The following is a description of a gene set: Binding to an identical protein to form a homodimer. species: Homo sapiens Human Gene Set: GOMF_PROTEIN_HOMODIMERIZATION_ACTIVITY, and this is the list of marker genes: ZNF318, IZUMO3, RAG1 (recombination activating 1), ACP3, CLTRN, ATG7, STARD3NL, IMPA1, PDXK, TYRP1, THBS1, PARK7, RIPK2, PEX11A, DEFA3, BOK, AMBP, MGLL, GPRASP3, BCL11A, KCNN2, TFAP4, WDR54, PDLIM4, AHR, FLRT3, NR4A3, TBC1D22A, PRPS1L1, PDCD6IP, NLGN4X, RPE, BANF1, DUSP29, PECAM1, FOXP3, SPPL3, IRAK3, PDXP, TOX3, SH3GLB1, HNF4A, GDNF, DIAPH3, HM13, RUNX1, TMEM132A, UGT1A4, CRPPA, SPPL2B, RBPMS2, SYNDIG1, MTHFD1L, GCA, NADK2, MECOM, TPD52L1, DCK, ECT2 (NCBI Gene Id 55710), STING1, CST7, ZDHHC2, ITPR1, UGT1A5, TCF3, IRAK1, SNX2, CREB3L3, XPA, PDGFB, SETMAR, PRPS1 (phosphoribosyl pyrophosphate synthetase 1), AIMP1, DGKD, ERP29, HTN3, GALE, HAND1, IKZF3, APOA4, PRMT8, AOX1, ASMT, BLOC1S6 (biogenesis of lysosomal organelles complex 1 subunit 6), DROSHA, PDGFRA, BNIP3L, CBS, STK25, TFRC, RBM11, GSTM4, SLC4A1, ABCB10, ZHX2, HSPB8, EEA1, COMMD1, JUP, LHPP, PADI2, CDSN, ST3GAL2, JDP2, RNF40, PML, CCDC66, GPD1, VEGFA, GNPTG, FCER1G, IRF3, HEYL, SLC11A1, ACVR1, MIXL1, GSTM1, PIP4K2A, ACHE, UGT1A8, MYOM1, CHMP4A, MFF, DDIT3, RRAGA, VAPA (NCBI Gene Id 9218), TENM3, ENDOG, ZNF397, GIMAP7, CR2, CARNMT1, TWIST1, TNNC1, SUPV3L1, ZBTB1, HOOK1, S100P, TKT, NUDT16, CAMK2A, ENO1, S100A11, ABCG1, CREB3, UGT1A1 (NCBI Gene Id 54658), PEX11B, USF2, MAG, TBX15, PDGFC, CDADC1, BAX, JAM3, TENM2, HIP1, PRKRA, FLNA, GCH1, NR2C1, GBP2, PON1, CAMK2D, ADRA2A, LILRB1, NECTIN1, RABEP1, SLC25A14 (solute carrier family 25 member 14), HOGA1, SMAD3, ZHX3, RASIP1, ATF2, CD4, SNX6, FLT4, MKLN1, S100A10, SP100, AGXT, HVCN1, TPCN1, MAP3K9, PKM, ARMCX5-GPRASP2, KYAT1, SRM, NEUROG1, XCL1, MTPAP, APOA2, HAND2, S100B, MMUT, SHMT1, TARBP2, ACOD1, KIF20B, FBLN5, ENG (endoglin, NCBI Gene Id 2022), ADRB3, YARS2, SDCBP2 (syndecan binding protein 2), MIGA2, SYT6, NTRK2, ZNF365, DARS2, GLDC, PAPSS1, CCL5, TTN, RAP1GAP, CASQ2, NR0B1, STAT1, KLRF2, PAFAH1B2, TGFB2, TPST1, HPGDS, S100A5, PSAP, S100A16, VPS25, DPYD, CEBPB, HSPB1, HSP90AB1, PTH1R, MTCL1, APP, ADA2, CEP131 (NCBI Gene Id 22994), CRYL1, TERT, ACTN4, ADCY8, IL17A (NCBI Gene Id 94918), SMCHD1, ODC1, TMEM266, SERPINF2, PHETA1, KCNN4, NUDT16L1, MMACHC, RELA, SLC8B1, HES1, PARP1, IDE, G6PD (glucose-6-phosphate dehydrogenase), INHBB, STK19, STUB1, XPNPEP3, APPL2, TPM1, ISCU, EXT1, ATF3, RAB11FIP2, FGFR1, UGT1A7, FMR1, ACOX2, WRN, CASR, HSD17B4, DNPH1, CARS1, ADRA2C, ACSL6, BHLHE41, JCHAIN, PAFAH1B3, MORC2, ACTN1, COL9A3, NR6A1, FUT9, CRYM, IL17F, PON3, ST6GAL1, SDS, DEFA6, CLEC2A, CEACAM5, ALDH1A3, ABCB7, TIMM9, PYCARD, AADAT, PKD2, PDGFA, CCDC103, GLB1, RABL3, PTPA, DPY30, SRGAP2C, IZUMO1, COQ9, PIP4K2B, ERN1, PPCS, CAT, GPD1L, NOG, SMAD4, ELAVL1, GRHL1, TP53BP2, SCARB2, GBP1, DAB2IP, APOA1, SNF8, PHETA2, TFAP2B, PANK3, MAP3K12, PTGS2 (prostaglandin-endoperoxide synthase 2), EIF2AK1, SOHLH1, THAP1, MUC13, LRP4, TXN, TAP1, ENPP1, C16orf89 (NCBI Gene Id 146556), PRTFDC1, SLK, TYW5, MID1, KNSTRN, SCLY, S100A1, IL17D, LCT, HPS4, EPM2A, MYH9 (myosin heavy chain 9), MSH6, HIP1R (NCBI Gene Id 9026), CRYAB, DCLRE1B, ACOT7, CHRNA7, MYOM3, NPC1L1, PLD6, FXR2, APOE, NUDT21, RAB11FIP3, GRPEL2, NR2F2, MAP3K11, CEP43 (NCBI Gene Id 11116), STK26, CITED1, GSTZ1, CEACAM1 (NCBI Gene Id 634), MMAA, CISD2 (NCBI Gene Id 56831), NAA60, ACADL, LYRM4, TPPP, CHUK, DPP4, EXD1, CACYBP, GUCY2D, S100A13, PGRMC1, TSG101, ABCD1, ADAM10 (NCBI Gene Id 102), NKX2-5, TREX1, BAK1, PTPRO, KYAT3, ECE1, RTN4, NOS2, IRAK2, TESC, AMHR2, MTMR1, UGT1A9, CPQ, APPL1, TLR9, THRSP, PSMF1, NRF1, CD300H, TPM4, FZD4, BST2, CSF1, MGAT4A, PHB2, FIBIN, TYROBP, CIB2, GYG1, USF1, NQO2, ATP2A1, SARS1, TMEM192, SRR, NPM1, TPD52L2, TPM2, RUVBL2, TPI1, DEFA5, TM4SF19, ABCD2, ANO1, SLC5A5, CHEK2, NR0B2, MSH2, TXNRD2, TPST2, MSTN, DNM1L, ERBB4, BHLHE40, F11R, SSBP1, CARD9, EPHX2, GBP3, SEPHS1, MLXIPL, IL6R, GID8, SOX6, POU3F3, UCP2, TPR, TIMM10, VAPB, PDCD6, DGAT2, FXR1, RACK1, WARS1, HNF1B, UGT1A6, HSD11B1, CNOT9, TSSK4, NRBP1, IDH1, UGT1A10, SRF, LPL, SNRPC (NCBI Gene Id 6631), HMGCS1, COL9A1, MAP3K13, ACOX1, QTRT2 (queuine tRNA-ribosyltransferase accessory subunit 2), CIDEA, TYR, XDH, ARNT, SLC3A2, TP53I3, CADM3, UGT1A3, CEP135, BLTP3B, MGAT2, SOD1, MSI1, CLCN1, ABCG2, NUDT5, S100Z, LRRFIP1, GZMA, MAP3K21, KCNH2, PDCD10, MSH3, ADD2, SMIM1, PCYT1A, COL2A1, CARD8, SP1, SFPQ, MYOD1, SLC25A27, ROM1, MZF1, ADIPOQ, HSPB6, PRPH2, MVD, MIGA1, PRDM9, PTPRT, RRM2, CEBPA, PSPH, SEPTIN12, WWTR1, TERF2, ZBTB7B, HESX1, GSTM2, DGCR8 (NCBI Gene Id 66034), HSD17B1, PITX2, HPD, CYP2R1, EXT2, RAB11FIP4, BIRC5, TBX18, CORO1A, FBXO4, TREX2, GTF2A2, RNF8, NECTIN2, TSC2 (TSC complex subunit 2), EPRS1, CAMK2B, ADRB2 (NCBI Gene Id 154), HARS1, MME, RBPMS, GBP5, TBX1, PDK2, SLC33A1, ZBTB4, CHMP4C, STOM, PANK1, TARS2, CEP57, BLM, PLEK (pleckstrin), ZBTB38, MLX, GSS, GLCE, DAPK3, PDE2A, TRNT1, GREM1 (NCBI Gene Id 7947), SPPL2A, CSF1R, SNX9, KYNU, MAPK4, MASP1, SOHLH2, CISD1 (CDGSH iron sulfur domain 1), NECTIN3, NFS1, RBM44, SPPL2C, DNTTIP1, SYNE1, ADD1, GHR, UXS1, TOP2A, DSCAML1, NOD1, HHEX, RIPK1, QTRT1, EFEMP2, AMELX, RCHY1, CDA, GSTA4, HNF1A, SLC30A8, BARD1, PEX7, MAP3K5, SLC39A13, HMOX1, INPP5F, ENSG00000274276, FAP, CBY1, CPOX, STK10, IMPA2, VIL1, CHKA, ABCG4, STK4, B2M, ZNF174, GRM6, HSP90AA1, ALDH3A2 (aldehyde dehydrogenase 3 family member A2), HLA-G, NPR3, TENM4, KIT, CIP2A, PRMT2, SLC51A, MID2, PLN, FICD, SLC26A5, ABCD3, KLHL7, IKBKB (inhibitor of nuclear factor kappa B kinase subunit beta), OXA1L, UBA5, GRHPR, TRPC6, KARS1, DAXX, PNPO, VWA1, FOXP2, JAML, AXIN1, MYO9B, GLIPR2, GLA, ZBTB16, LILRB2 (leukocyte immunoglobulin like receptor B2), ALS2, GOLGA5, GALM, TENM1, CAV2, CALCOCO2, KMT2A, CAMK2G (NCBI Gene Id 818), VPS4B, GSTM3, ATIC, RDH5, DEFA4, COL9A2, SYT10, BNIP3, BMPR1A, DNM1, ERCC5, NAALADL1 (NCBI Gene Id 10004), MAP3K10, STARD3, UPB1, NFE4, CD247, MTUS2, SNX1, TRIM8, FZD9, GRPEL1, ZNF396, STAT5B, NAGA, TRIM5, GBP4, GGCT, STAT3, NLRC4, GADD45A, TMIGD1, CENPF (NCBI Gene Id 51468), GEN1, MFSD1, PSMD7, GDF15, PAXX, CADM1, TPD52, S100A6, NTRK1, TRIM9 (tripartite motif containing 9), NACC2, PON2 (paraoxonase 2), HIF1AN, ANG, TERF1, ABCB9, TYMP, XPNPEP1, CGAS, TRIM37, SIRT6, CCDC88A, PRPS2, DST (dystonin), CHMP4B, AKT1, CER1, MAD2L1 (mitotic arrest deficient 2 like 1), FGFR2, SRGAP2, STC2, LDB1, LRRK2, AOC1 (amine oxidase copper containing 1), ZDHHC3, IKBKG, GLUD1, NDP, CHMP1A, CANT1, FECH, SLIT2, EXD2, CUBN, CLN6, KHK, LRP6